The following is a description of a gene set: This event has been computationally inferred from an event that has been demonstrated in another species.<p>The inference is based on the homology mapping from PANTHER. Briefly, reactions for which all involved PhysicalEntities (in input, output and catalyst) have a mapped orthologue/paralogue (for complexes at least 75% of components must have a mapping) are inferred to the other species. Reactome Pathway: RHOBTB2 GTPase cycle electronically inferred by orthology from the curated human pathway part of: RHOBTB GTPase Cycle species: Mus musculus, and this is the list of marker genes: Msi2, Rbmx (RNA binding motif protein, X chromosome), Tmod3, Cct6a, Cct7, Twf1, Cdc37, Cct2, Txnl1